The following is a description of a gene set: species: Mus musculus Genes predicted to be targets of miRBase v22 microRNA mmu_miR_1191b_5p in miRDB v6.0 with MirTarget v4 prediction scores > 80 (high confidence targets). from publication Chen Y, Wang X (PMID 31504780) Mouse Gene Set: MIR_1191B_5P, and this is the list of marker genes: Nfam1, Phf6, Zbtb44, Abraxas2, Plcb1, Fam76b, Hivep2, Btg1, Foxn4 (NCBI Gene Id 243222), Fbxo45, Strn3, Chid1, Ubtd2, Pgm2, Nipal4, Snx17, Nol6, Slc27a4, Gria4, Ano4, Krtap31-3, Nek9, Kcnma1, Ptpre, Tcaim, Slc4a4, Kctd14, Ythdc2, Lrtm2, Suz12, Cdk14, Gopc, Nuf2, Mrps10, Arrdc3, Gpm6a, Cxcl12, Gabpa, Eif4a2, Ammecr1